Given this list of marker genes FASTKD2, MIURF, MTG2, RPL11, MRM2, EIF6, NOP2, DDX28, RPF2, DHX30, RPL5, RPL10L, MRTO4, NOP53, MTG1, MDN1, RRS1, BOP1, BRIX1, RPL24, RCC1L, here is a description of the gene set: studied in species Homo sapiens The aggregation, arrangement and bonding together of constituent RNAs and proteins to form the large ribosomal subunit. Human Gene Set: GOBP_RIBOSOMAL_LARGE_SUBUNIT_ASSEMBLY